The following is a description of a gene set: Any process that activates or increases the frequency, rate, or extent of a chronic inflammatory response. studied in species Mus musculus Mouse Gene Set: GOBP_POSITIVE_REGULATION_OF_CHRONIC_INFLAMMATORY_RESPONSE, and this is the list of marker genes: Ido1, Lta, Pde5a, Adora2b, Tnf